Given this list of marker genes RYBP, AUTS2, PCGF3, CSNK2A2, YAF2, PCGF5, CSNK2B, RNF2, FBRS, DCAF7, CSNK2A1, RING1, here is a description of the gene set: Blocking ubiquitination of H2AK119 by CK2. Pathway ID: N01620. Pathway type: Reference. Pathway class: nt06523 Epigenetic regulation by Polycomb complexes. Human Gene Set: KEGG_MEDICUS_REFERENCE_BLOCKING_UBIQUITINATION_OF_H2AK119_BY_CK2 studied in species Homo sapiens Pathway Definition from KEGG: CK2 -| PRC1.3,PRC1.5 -- H2AK119+UB